Given this list of marker genes IDH3A, ARSG, PROM1, MFSD8, CFH, CFI, KLHL7, GUCY2D, CCDC28B, PRPH2, RAX2, AIRE, TTLL5, RPGR, ARL6, POMGNT1, KIF3B, IFT172 (NCBI Gene Id 26160, intraflagellar transport 172), CHM, KIZ, TIMP3, RS1, BBS1, EFEMP1, CFAP418, PRPF8, PRPF31, TLCD3B, KIAA1549, SAMD7, CWC27, GUCA1A, here is a description of the gene set: Fundus autofluorescence (FAF) is a non-invasive retinal imaging modality used in clinical practice to provide a density map of lipofuscin, the predominant ocular fluorophore, in the retinal pigment epithelium. Autofluorescent patterns result from the complex interaction of fluorophores such a lipofuscin, which release an autofluorescent signal, and elements such as melanin and rhodopsin, which absorb the excitation beam and attenuate autofluorescence. Other structures such as retinal vessels and the crystalline lens may also influence autofluorescence through blocking and interference. species: Homo sapiens Abnormal fundus autofluorescence imaging Human Gene Set: HP_ABNORMAL_FUNDUS_AUTOFLUORESCENCE_IMAGING